Given this list of marker genes EPHX1, EPHX2, EPHX3, ALOX12, ALOX5, here is a description of the gene set: studied in species Homo sapiens The chemical reactions and pathways involving epoxides, compounds in which an oxygen atom is directly attached to two adjacent or non-adjacent carbon atoms of a carbon chain or ring system; thus cyclic ethers. Human Gene Set: GOBP_EPOXIDE_METABOLIC_PROCESS